Given this list of marker genes ALAD, COL5A1, CACNA1D, SLC22A12, IL18BP, SDHC, GK (glycerol kinase), SDHB, TP53, SLC7A7, GLA, PINK1, ALDOB, SDHD, ETFB, KIF1B, MGME1, EXT2, VPS13C, PODXL (podocalyxin like), UCHL1, CYP11B1, EDNRA, CLCN2 (chloride voltage-gated channel 2), CFI, LIG3, HMBS, CPOX, DNAJC6, CD46, SLC2A9, RRM2B, SDHAF2, NR0B1, NAGS, CDKN2C, SYNJ1, POLG, KCNJ5, TYMP, CFH, MAX, CYP11B2, ATP1A2, FH, SLC1A3, SAA1, COL1A1, SI, SERPING1, TMEM127, PRKN, RET, DLST, CTRC, LPL, PARK7, PTPN22, ESR1, NPPA (NCBI Gene Id 90230), VHL, RRM1, SPINK1, CDKN2B, NF1, CDKN1B, CDKN1A (NCBI Gene Id 1026), FSHR, HELLPAR, PPOX, TET2, LRRK2, RYR1, SNCA, SLC25A11, SCN5A, MEN1, KIT, SDHA, ETFDH, DNMT3A, EPAS1, HTRA2, TNF, PHKA2, MDH2, ASXL1, SCN2A, SRSF2, PKHD1, TRANK1, APC (NCBI Gene Id 324), ETFA, FAS, STAT3, PHKB, COL5A2 (NCBI Gene Id 1290), KCNA1, KCNQ2, PHKG2, here is a description of the gene set: Nausea studied in species Homo sapiens Human Gene Set: HP_NAUSEA A sensation of unease in the stomach together with an urge to vomit.